Given this list of marker genes TTPA, ADGRA2, ABCB1, CTNNB1, WNT7A, MFSD2A, LSR, NDP, LRP5, ADGRG6, RECK, BPGM, FZD4 (NCBI Gene Id 8322), MXRA8, FOXP3, CLDN3, VPS4B, here is a description of the gene set: Establishment of the barrier between the blood and the brain. The cells in the brain are packed tightly together preventing the passage of most molecules from the blood into the brain. Only lipid soluble molecules or those that are actively transported can pass through the blood-brain barrier. studied in species Homo sapiens Human Gene Set: GOBP_ESTABLISHMENT_OF_BLOOD_BRAIN_BARRIER